Given this list of marker genes R3HDM1, PHYKPL, SLC39A9, PGGT1B, DIO2, FMN1, CTNNA1, MCPH1, GLIPR1, SEMA3D, POLK, ARID1B, TAFA4, SACS (sacsin molecular chaperone), ZC3H6, FNTA, SERTAD4, PDSS1, ZNF544, DYNLRB1, CWC15, TDG, CLIP1, PLP1, GLDN, FRYL (FRY like transcription coactivator), NFATC1, OLFM3, BAZ2A, SPDYA, ARHGAP32, UTRN, PDZRN3, CCL28, ANKS1A, OSTM1, AKTIP, MFSD4B, RABIF, CTSG, EPB41L2, MOB3B, GTF3C3 (general transcription factor IIIC subunit 3), CAMK4, EMB, COL4A3, ZSWIM6, ZC3H7A, HMBS, BIRC3, MAGT1, BMP2, FMNL2, FCGR2A, FBXL3, KIF13A, TESK2, RAP2A, RIMKLB, RAB5C (NCBI Gene Id 5878), ANKRD42, SLC7A11, CXCL11 (NCBI Gene Id 6373), SLC12A2, MINAR1, DCLK1, SRSF2, PTGER4, SLC6A13, TSC22D2 (NCBI Gene Id 9819), PRMT6, PDE8A, MIER3, SP3, PFN2, CEACAM1, ARID1A, SORBS1, GCLM, AVPR1A, IKZF4, MTMR4, FRMD3, AMMECR1, CBLN2 (cerebellin 2 precursor), AR, SNX16, AP1S3, SEPTIN11, NEDD4, PARG, AKAP6, SOX30, SH3BGRL, RINT1, GFPT2, HGF, RCC1L, SLC25A30, PLPPR5, ATF1, ZNF366, LINC03103, EPB41L3, FILIP1, IDNK, TULP4 (NCBI Gene Id 56995), here is a description of the gene set: Human Gene Set: MIR487B_5P from publication Chen Y, Wang X (PMID 31504780) species: Homo sapiens Genes predicted to be targets of miRBase v22 microRNA hsa-miR-487b-5p in miRDB v6.0 with MirTarget v4 prediction scores > 80 (high confidence targets).